Given this list of marker genes NFKB2, GCNT1, APOA4, SERPINB3, H3C10, CCDC106, BMAL1, CTSK, PDE1A, TNF, GH2, ARSB, MX1, LRRC17, PCSK2, KCNA1, SCGB2A1, CKMT1B, TOE1, CREG1, HAO1, FANCC, IGLL1, NR2C2, CTSA, ZNF415 (zinc finger protein 415), here is a description of the gene set: species: Homo sapiens Genes in the cancer module 340. Human Gene Set: MODULE_340